The following is a description of a gene set: The directed movement of a motile cell or organism in response to an external stimulus. Mouse Gene Set: GOBP_TAXIS studied in species Mus musculus, and this is the list of marker genes: Nod2, Ccr9, Ccn3, C3ar1, Dpp4, Ephb1, C5ar1, Sema4c, Sell, Scrib, Gpr183 (G protein-coupled receptor 183), Ppia, Ifng, Plec, Ear6, Ccl21d, Ccl11, App, Rtn4r, Fpr1, Rho, Pla2g6, Slc8b1 (NCBI Gene Id 170756), Mcu, Slc12a2, Adam10, Sema3d, Aif1, BC037156, Trem1, Cxcl11, Ccl6, Hbegf, Tafa4, Ctsg, Mycbp2, Cxcr4, Prkd1, Tbr1, Jaml, Ppm1f, Stx3, Cnr2, Plxna3, Pikfyve, Ccr6, Edn2, Ear2, Cxcr5, Gas6, Hoxb9, Fpr-rs3, Slamf1, Ptk2b, Cd74 (CD74 antigen (invariant polypeptide of major histocompatibility complex, class II antigen-associated)), Hspb1, Dapk2, Opn4, Pik3c2g, Akt2, Tirap, Nova2, Jam3, Akirin1, Il17rc, Stk39, Xcl1, Eng, Ednrb, Il16, Trpm4, Ano6, Fpr-rs4, Cyp7b1, Ppib, Agr2, Edn3, Lrp1, Dusp1, Crkl, Ripor2, Fgf8, Chga, Ccl28, Blvra, Fpr-rs7, Nbl1, Kdr, Klrk1, Robo2, Defb48, Pip5k1c, Pou4f2, Fgf16, Prkcd, Bsg, Adgra2, Mmp9, Hmgb1, S100a9, Cmtm8, Wnt7b, Igfals, Lgmn, Perp, Ffar2, Gbf1, Ccl17, Cmklr1, Cxcl17, Csf3r, P2ry12, Ccl21b, Ccl5, Ackr2 (NCBI Gene Id 59289), Gpr18, Ptpro, Coro1a, Lef1, Tnfsf11, Cmtm7, Fgf18, Arhgef16, Trpm2, Dnm1l, Ninj1, Slamf8, Cxcl12, Bin2, Defb33, C5ar2, S100a8 (NCBI Gene Id 99591), Fcer1g, Ccl20, Dock4, Retnlg, Nox1, Pik3cd, Fn1, Mif, Lect2, Arrb2, Ccl1, Gpr15lg, Scg2, Fes, Defb8, Clxn, Epha2, Ptn, Cxcr1, Ccr7, Itga1 (integrin alpha 1), Tsc2, Ager, Tgfb1, Ppbp, Wnt5a, Ptgr1, Defb25, Cyp19a1, Cx3cr1, Cxcr3, Nr4a1, Calr, Sema4b, Ccl4, Cxcl1, Gpsm3, Efna5, Bmp4, Ntn1, Fezf2, Mdk, Pip5k1a, Il1b, Pdgfrb, Smoc2, Defb3, Sema3b, Msmp, Mmp28, Cxcl2, Mtus1, Shh, Itgb2l, Spi1, S1pr1, Ch25h, Tiam1, Artn, Rpl13a, Prkca, Dock2, Cxcl14, Mstn, Itga2, Itgb3, Fgf1, Atoh7, Lpar1, Il34, Pgf, Lgals9, Ccr3 (C-C motif chemokine receptor 3), Flrt2, Fpr2, Kit (KIT proto-oncogene receptor tyrosine kinase), Swap70, Sema3g, Thbs4, Mst1, Sema7a, Bcar1, Lbp, Ccl21f (C-C motif chemokine ligand 21F), Tgfb2, Ear14, Il4, Ptprj, Dscam, Ccr8, Cmtm5, Wasl, Saa3, Cx3cl1, Cxcl13, Plxnb3, Tnfsf14, Slit1, Lgals3, Sema4g, Sema4f, Prkd2, Zfp580, Ccl19-ps4, Agrn, Rac3, Ecscr, Fpr3, Agtr1a, Cmtm3, Slc37a4, Ythdf1, Fgf2, Ccl9, Il23a, Cxcl15, Oxsr1, Ccl12, Sema3f, Nrp1, Ccl24, Prok2, Ccr5, Cysltr1, Hc, S100a4, Nrg3, Tpbg, Robo1, Ccl3, Parva, Hgf, Ccl26, Vegfa, Cxcl16, F7, Rnase2b, Nrp2, Lgr4, Slit2, Vegfc (NCBI Gene Id 22341), Nup85, Pdgfra, Ccl21a, Gstp1, Cklf, Ryk, F2rl1, Ackr4, Trpv4, Pdgfd, Ptk2, Mpp1, Rarres2, Defb47, Ccn1, Rtn4rl1, Flrt3, Ednra, Defb7, Xcr1, Vcam1 (NCBI Gene Id 22329), Il17b, Trem2, Rnase2a, Stap1, Itgam, Cyrib, Dysf, Ccr1l1, Pdgfb (platelet derived growth factor, B polypeptide), Enpp2, Plxna4, Pde4b, Wnk1, Thbs1, Defb14, Ccl19-ps1, Sema4a, Ccl22, Nckap1l, Vegfb, Mospd2, Cmtm2b, Pde4d, Vav3, Lrp2, Ccl19-ps6, Ccl21e, Casr, Abcc1, Spp1, Ccl19-ps3, Csf1, Csf1r, Cxcr6, Anxa1, Cxcl5, Slamf9, Pik3cg, Lsp1, Gm6040, Lox, Tmem102, Maco1, Gpr35, Epha7, Fgf10 (fibroblast growth factor 10), Rab13, Snai2, Efnb2, Alkbh1, Sucnr1, Ccr1, Cxcl10, Vav1, Defb4, Tnfaip6, Lyst, Robo3, Hmgb2, Fcgr3 (Fc receptor, IgG, low affinity III), Il12a, Plekhg5, Sema3c, Camk1d, Flt1, Mmp2, Ptgdr2, Ccl19, Cxcl9, Ackr3, Bst1, Gab1, Creb1, Or10j5 (olfactory receptor family 10 subfamily J member 5), Coro1b, S100a14, Sema3e, Pdgfa, Sema5a, Pf4 (platelet factor 4), Serpine1, Pla2g7, Ccl19-ps5, Ccr10, Angpt2, Dusp3, Cxadr, P2rx4, Fer (NCBI Gene Id 80679), Cttn, Nedd9, Crk, S100a7a, Edn1, Elmo2, Defb6, Defb46, Fgf7, Cxcl3, Mapk1 (NCBI Gene Id 98012), Fpr-rs6, Tubb2b (tubulin, beta 2B class IIB), Syk, Wnt3a, Arhgef5, Egr3, Ccr2, Lyn, Rps19, Myo9b, Prex1, Rin3, Fgfr1, Hdac6, Stx4a, Rhoa (ras homolog family member A), Fgf4, Cmtm2a, Cdh13 (cadherin 13), Creb3, Ntrk3, Mapk3, Ptpn2, Dpep1, Plgrkt, St6gal1, Met, Hrg, Vegfd, Tymp, Itgb2, Padi2, Defb5, Adam17, Sema4d, Notch1, Trem3, Colec10, Cxcr2, Hsd3b7, Ccl8, Kif21a, Apoa1, Srp54a, Ear1, Adam8, Usp14, Ccr4, Ccl2, Ear10, Tnfsf18, Sema3a, Smad3, Agtr1b, Amot, Gm5849, Ccl7, Bmpr2, Sbds, Alox5, Ptafr, Megf8, Tmsb4x, Prkcq, Rac1, Nrg1, Ccl25, Rhog, Rac2, Ccrl2, Gstp2, C1qbp, Ntf3, Itga9, Slit3 (NCBI Gene Id 632373), Ccl27a, Grem1, Angpt1, Unc5c, Il17ra, Wnt3, Itgav